Given this list of marker genes JAK2, KLF4, KAT8, ERCC1, MYO1E, here is a description of the gene set: studied in species Homo sapiens Human Gene Set: GOBP_POST_EMBRYONIC_HEMOPOIESIS The stages of blood cell formation that take place after completion of embryonic development.